Given this list of marker genes AMPD2, AK2, GART, PFAS, AMPD3, AK4, PAICS, AMPD1, ADK, ATIC, XDH, AK1, NT5C1A, AK3, ADA, NT5E, ADSS2, PPAT, NUDT2, HPRT1, ADSL, APRT, ADSS1, here is a description of the gene set: studied in species Homo sapiens Human Gene Set: GOBP_AMP_METABOLIC_PROCESS The chemical reactions and pathways involving AMP, adenosine monophosphate.